Given this list of marker genes Slc13a1, Slc13a4 (solute carrier family 13 (sodium/sulfate symporters), member 4), here is a description of the gene set: studied in species Mus musculus This event has been computationally inferred from an event that has been demonstrated in another species.<p>The inference is based on the homology mapping from PANTHER. Briefly, reactions for which all involved PhysicalEntities (in input, output and catalyst) have a mapped orthologue/paralogue (for complexes at least 75% of components must have a mapping) are inferred to the other species. electronically inferred by orthology from the curated human pathway Reactome Pathway: Sodium-coupled sulphate, di- and tri-carboxylate transporters part of: SLC-mediated transport of inorganic anions